Given this list of marker genes Rela, Sphk2, Chrna7, Apoe, Epha4, Gsk3a, Nfe2l2, Smpd3, Csnk1e, Casp3, Pla2g6, Rock2 (Rho-associated coiled-coil containing protein kinase 2), Slc2a13, Tnf, Ifng, Clu, Abca2, Prkcd, Enpp7, Eed, Tnfrsf1a, Efna1, Nsmaf, Gsap, Sirt3, Rack1, Lrrtm3, Eif2ak3, Ccn1, Ifngr1, Abcg1, Zfp750, Picalm, Sp1, here is a description of the gene set: Mouse Gene Set: GOBP_POSITIVE_REGULATION_OF_AMIDE_METABOLIC_PROCESS Any process that activates or increases the frequency, rate or extent of the chemical reactions and pathways involving amides. species: Mus musculus